The following is a description of a gene set: Insistence on sameness species: Homo sapiens Human Gene Set: HP_INSISTENCE_ON_SAMENESS, and this is the list of marker genes: NLGN3, GLRA2, MECP2, FOXP1, NLGN4X, SNRPN